The following is a description of a gene set: Genes up-regulated in comparison of NKT cells versus neutrophils. Each fraction of mouse hematopoietic cells was purified by cell sorting from bone marrow of 8-week-old C57BL/6 mice, and its gene expression was analyzed. Human Gene Set: GSE27786_NKTCELL_VS_NEUTROPHIL_UP studied in species Homo sapiens from publication Konuma T, Nakamura S, Miyagi S, Negishi M, Chiba T, Oguro H, Yuan J, Mochizuki-Kashio M, Ichikawa H, Miyoshi H, Vidal M, Iwama A (PMID 21540074), and this is the list of marker genes: ADSL, NMI, NDUFAF8, PARP2, MVB12A, DMRT3, BAX, ST13, SMARCA5, MAP4K1 (NCBI Gene Id 11184), UBR1, TIMM22, JAK2, RGS1, MDN1, TMEM39B, CKB, KDM4D, UBE3A, GNL2, MED28, THAP7, COX4I1, RNF220, DRG2, CHST14, TXN2, ERCC5, ODC1, SETDB2, RCBTB2, SATB1, PSIP1, TENT5A, GALNT1, LAX1, ZMYM4 (zinc finger MYM-type containing 4), PPIL2, ARHGAP18, ARF6, SOCS2, CUL1, BMAL1, MTA3, PABIR2, NSMCE4A, MRPL15, REV3L, MBOAT1, LRRC72, PPA2, ITGB3BP, NUP155, PPP2R2A, DBP, TBCCD1, TMEM135, SEPTIN6 (NCBI Gene Id 23157), PFKL, POGLUT2, COPS3, FNBP4, NXPE3, EIF4H, ECSIT, CHORDC1 (cysteine and histidine rich domain containing 1), LINC01160, THADA, NLK, TAP1 (transporter 1, ATP binding cassette subfamily B member), RBM14, PRPSAP1, NPC2, EEF1E1 (eukaryotic translation elongation factor 1 epsilon 1), MTCP1, FRA10AC1, ZBTB8A, MRPL41, VPS41, FAM98A (NCBI Gene Id 25940), DCAF1, ZNF777, AEBP2 (AE binding protein 2), ADGRE5, SCFD2, SNRPB2, LUC7L3, PHB1, PPFIA1, IPO5, ZDHHC21, KIAA1671-AS1, DDX59, ZFP90, DCUN1D2, TBC1D17, SPRYD4, AKIP1, TMEM70, METTL15, TAF4B (NCBI Gene Id 6875), C10orf88, MYO1E, NUP214, ZNF708 (NCBI Gene Id 7562), PTPN4, PRPF39, TAS1R2, TARS2, MYEF2 (NCBI Gene Id 56051), MECR, CCSER2, ATPAF1, MAN1A2, PJA1 (praja ring finger ubiquitin ligase 1), VEZF1, RBBP4, ITGA2, CCDC86, RCBTB1, NENF, LRRC42, TNFSF10, LSM7, DUSP12, ASXL2, PDHB, FAM86B2 (NCBI Gene Id 653333), CEP68, IL21R, KNOP1, INPP5B, BLTP2, TSKS, PPP1R7, SLC30A1, RLIM, ATP10A, LZTFL1, ZNF598, SART1 (spliceosome associated factor 1, recruiter of U4/U6.U5 tri-snRNP, NCBI Gene Id 9092), SF3A3 (NCBI Gene Id 10946), MX2, ANAPC10, PML, DDX28, GNB1L, TMEM177, ADI1, RCC1L, DDX24, MRPL2, RFX5, SNRPF, ILF2, RFC5, ZKSCAN3, DCAF5, RTN4RL1, STARD10, PTCH1, PRORP, LCMT2, PHF6, TCF25, PARP9, ECE1, GMPPA, RRP9, BSCL2, NOL12, CCT6A, POLD2 (NCBI Gene Id 5425), PATJ, KDSR, MDP1, RITA1, TBL1X, BORCS5, UQCC6, NFATC1, SLC35A4, S1PR1 (NCBI Gene Id 51546), GDPGP1, RPTOR, ALKBH1, CRYBG1 (crystallin beta-gamma domain containing 1), ZC3HAV1, MRE11, COA5, AVPI1, BEND3, HOOK1, ZNF692, ENTPD6, YBX1, PCNT, CNDP2, TNFAIP3, SAR1A